The following is a description of a gene set: species: Homo sapiens Human Gene Set: REACTOME_ACTIVATED_NTRK2_SIGNALS_THROUGH_FRS2_AND_FRS3 Activated NTRK2 signals through FRS2 and FRS3, and this is the list of marker genes: SOS1, KRAS, NTRK2, PTPN11, NTF4, GRB2, NRAS, HRAS (NCBI Gene Id 338029), FRS2, FRS3, BDNF